The following is a description of a gene set: Any process that increases the rate, frequency or extent of a type I interferon-mediated signaling pathway. species: Homo sapiens Human Gene Set: GOBP_POSITIVE_REGULATION_OF_TYPE_I_INTERFERON_MEDIATED_SIGNALING_PATHWAY, and this is the list of marker genes: ZBP1, IRF3, LSM14A, IRF7, RBM47, TRIM6, NLRC5, IKBKE, UBE2K, MAVS, TRIM41, USP27X (NCBI Gene Id 389856), RNF185, WNT5A, FADD, TBK1, USP29, STING1, MMP12, TRIM56